The following is a description of a gene set: electronically inferred by orthology from the curated human pathway part of: Signal Transduction studied in species Mus musculus Reactome Pathway: Signaling by TGFB family members This event has been computationally inferred from an event that has been demonstrated in another species.<p>The inference is based on the homology mapping from PANTHER. Briefly, reactions for which all involved PhysicalEntities (in input, output and catalyst) have a mapped orthologue/paralogue (for complexes at least 75% of components must have a mapping) are inferred to the other species., and this is the list of marker genes: Timp1, Cbl, Nedd8, Acvr1c, Mmp14, Tgif1, Acvrl1, Smad9, Ube2d1 (ubiquitin-conjugating enzyme E2D 1), Grem2, Gipc1, Mapk3, Smad7, Itgb5, Amh, Smurf1, Fkbp1a, Tfdp1, Chrdl1, Bambi, Acvr2a, Fstl1, Smad3, Arrb2, Psen1, Itgb8, Ltbp2, Mtmr4, Fstl3, Inhbb, Inhba, Gdf2, Tgfb1, Atp1b4, Psenen, Pard3, Ltbp3, Smad1, Ncor2, Rnf111 (ring finger 111), Zfyve16, Fgf2, Smad6, Ubb, Rps27a, Cdk8, Bmp10, Men1, Smurf2, Wwtr1, Snw1, Nog